The following is a description of a gene set: A ubiquitin ligase complex in which a cullin from the Cul2 subfamily and a RING domain protein form the catalytic core; substrate specificity is conferred by an elongin-BC adaptor and a SOCS/BC box protein. species: Homo sapiens Human Gene Set: GOCC_CUL2_RING_UBIQUITIN_LIGASE_COMPLEX, and this is the list of marker genes: COMMD1, PRAMEF9, KLHDC10, ZYG11A, PRAMEF11, PRAMEF22, PRAMEF13, LRRC75A, PRAMEF19, PRAMEF14, ZSWIM8, FEM1A, PRAMEF1, ZER1, FEM1C, PRAMEF20, PRAMEF27 (NCBI Gene Id 101929983), PRAMEF4, PRAMEF2, FEM1B, GLMN, ZSWIM5, ELOC, PRAMEF25, ZYG11B, PRAME, PRAMEF26, KLHDC2, ZSWIM6, ELOB, PRAMEF8, RBX1, PRAMEF6, ASB4, KLHDC3 (NCBI Gene Id 116138), PRAMEF7, PRAMEF12, PRAMEF18, PRAMEF33, PRAMEF10, ZSWIM4, ARIH1, CUL2, PRAMEF5, PRAMEF15, APPBP2, PRAMEF17